Given this list of marker genes CTNNB1, RAB5A, CABLES1 (NCBI Gene Id 91768), RIN2, NME1, GNA12, SNX1, EGF, ADAM10, SRC, GNA13, BDNF, IQGAP1, CBLL1, CDC42, MET, CDH1, CTNND1, ZBTB33 (NCBI Gene Id 10009), RAB7A, CDH2, JUP, IGF1R, PTPN6, GFRA1, ARF6, CREBBP, DSP, NTRK2, IGF2, ROBO1, MMP7, ABL1, MMP3, CTNNA1, FYN, GDNF, PTPN1, CASP3, EGFR, SLIT1, HRAS, RAC1, RET, HGS (NCBI Gene Id 9146, hepatocyte growth factor-regulated tyrosine kinase substrate), MEP1B, TIAM1, DNM2, here is a description of the gene set: Posttranslational regulation of adherens junction stability and dissassembly studied in species Homo sapiens from publication Schaefer CF, Anthony K, Krupa S, Buchoff J, Day M, Hannay T, Buetow KH (PMID 18832364) Human Gene Set: PID_AJDISS_2PATHWAY